The following is a description of a gene set: Human Gene Set: chr15q21 species: Homo sapiens, and this is the list of marker genes: RN7SKP139, ENSG00000260937, MTND5P40, TEX9, ENSG00000259200, DNAAF4, RPL15P19, RN7SKP95, RNU6-94P, TMOD2, GCOM1, SLC24A5, FGF7, MINDY2-DT, SPPL2A, RN7SL494P, FBN1-DT, FBN1, DUT-AS1, RFX7, ENSG00000261709, RNU6-1332P, CTXN2-AS1, LEO1, SPG11, COPS2, HDC, RNU6-844P, FAM227B, RN7SL568P, GLDN, ENSG00000304772, CTXN2, DUOXA2, ALDH1A2, MIR7973-2, RN7SKP101, AP4E1, PYGO1, CGNL1, ATOSA, LYSMD2, HNRNPA1P74, LINC03065, SNORA41B, ARPP19, SLC30A4-AS1, PIGBOS1, MNS1, SECISBP2L, NDUFAF4P1, DUOX1, ENSG00000259754, RN7SL577P, MYO5A, DUOXA1, PIGB, RNU1-78P, DNAAF4-CCPG1, EIF3J-DT, C15orf48, RNU6-90P, MIR4713, AFG2B, LINC01413, SQOR, EEF1A1P22, ATP8B4, POLR2M, CCPG1, DCAF13P3, MIR4713HG, SLC27A2, RNA5SP394, MIR1266, WDR72, LIPC, BLOC1S6 (biogenesis of lysosomal organelles complex 1 subunit 6), SORD2P, RNU6-1014P, SEMA6D, MYEF2, MIR628, ENSG00000259203, ENSG00000307269, EIF3J, RPL7AP62, CNOT6LP1, RNA5SP395, PRTG, LINC00926, SLC28A2-AS1, RNU6-1108P, EEF1B2P1, ENSG00000259588, RN7SL354P, MTCO3P23, MAPK6-DT, TNFAIP8L3, DUT, RSL24D1, MIR4712, USP50, RNU6-966P, MYZAP, ENSG00000288645, LINC02490, RNU6-953P, HMGB1P51, SHC4, SLC28A2, RNU2-53P, SCG3, SLC30A4, SLC12A1, RNU1-119P, MIR4716, USP8, HSP90AB4P, NEDD4, GATM, CYP19A1, MTND3P12, HMGB1P33, UNC13C, TRPM7 (NCBI Gene Id 54822), TMOD3 (tropomodulin 3), CEP152, HNRNPA3P11, MIR147B, RAB27A, DUOX2, ENSG00000259188, MIR7973-1, RN7SL307P, B2M, MINDY2, MAPK6, ALDH1A2-AS1, ONECUT1, MYO5C, TERB2, GABPB1-AS1, MTND5P32, AHCYP7, CD24P2, BCL2L10, RNU6-449P, ADAM10, DMXL2, HMGN2P46, GABPB1, TCF12-DT, ENSG00000304751, KRT8P24, LINC01491, GNB5, AQP9, PIERCE2, SNORD13D, RPSAP55, RPL32P30, TRIM69, LIPC-AS1, PATL2, DTWD1, CERNA1, ZNF280D, SHF, TCF12, SORD (NCBI Gene Id 6652), RNU6-1287P, NDUFB10P1, ENSG00000238819, GALK2, EID1, MTCYBP23, DPPA5P2, GABPB1-IT1, H3P39, SNORD3P1